Given this list of marker genes TRAIP, ZNF480, PCGF3, TOMM20, PTBP2, CRTC3, CREBZF, FLOT2, RABGAP1, ZNF513, EPB41L2, COX7A2, JAKMIP3, BRD10, CD4, HIF1A, RRAGD, MSL1, ERBIN, DLG5, CCT2, SLAIN1, OAS1, ATOSA (NCBI Gene Id 56204), NUBP1, CSGALNACT1, APPBP2, CSF3R, USF3, BRWD1 (NCBI Gene Id 54146), LRFN1, PUM2, FOXO3, ARHGEF38, METTL4, CHD3, CHCHD7, GAS2L1, PCDH7, GYS1, VAPA, CLIP2, NEK1, YIPF5, GABRR1, GSS, ATP2B4, MEIS2, NR0B2, OSBPL8, MED13L, KCNMB2, PIGM, AHCYL1, RBM20 (RNA binding motif protein 20), DCP1A, RTL8A, YBX1, PATZ1, DCX, CGGBP1, SCN1A, RALGDS, CCL19, SLC23A2, GLYR1, CBFB, SLC22A2, SYT15, IYD, GLTP, AREL1, FRMD5, ERC1, POGLUT1, TMEM202, ABTB2, TMEM115, PTPRA, WBP4, OTUB2, ZDHHC5, TMEM184B, NECAP2, AZIN1, ARHGEF2, SPPL3, CMTM6, COX6A1, MOSMO, FAM181B, ARHGEF40, GPR37L1, FBXL20, NEBL, here is a description of the gene set: Human Gene Set: MIR7152_3P from publication Chen Y, Wang X (PMID 31504780) studied in species Homo sapiens Genes predicted to be targets of miRBase v22 microRNA hsa-miR-7152-3p in miRDB v6.0 with MirTarget v4 prediction scores > 80 (high confidence targets).